Given this list of marker genes Pdzd11, Btd, Slc5a6, Mccc2, here is a description of the gene set: studied in species Mus musculus Reactome Pathway: Biotin transport and metabolism electronically inferred by orthology from the curated human pathway part of: Metabolism of water-soluble vitamins and cofactors This event has been computationally inferred from an event that has been demonstrated in another species.<p>The inference is based on the homology mapping from PANTHER. Briefly, reactions for which all involved PhysicalEntities (in input, output and catalyst) have a mapped orthologue/paralogue (for complexes at least 75% of components must have a mapping) are inferred to the other species.